The following is a description of a gene set: species: Homo sapiens Tumor growth is associated with a profound alteration of myelopoiesis, leading to recruitment of immunosuppressive cells known as myeloid-derived suppressor cells (MDSCs). Analyzing the cytokines affecting myelo-monocytic differentiation produced by various experimental tumors, we found that GM-CSF, G-CSF, and IL-6 allowed a rapid generation of MDSCs from precursors present in mouse and human bone marrow (BM). BM-MDSCs induced by GM-CSF+IL-6 possessed the highest tolerogenic activity, as revealed by the ability to impair the priming of IFN- -producing CD8+ T cells upon in vivo adoptive transfer. Moreover, adoptive transfer of syngeneic, GM-CSF+IL-6-conditioned MDSCs to diabetic mice transplanted with allogeneic pancreatic islets resulted in long term acceptance of the allograft and correction of the diabetic status. Cytokines inducing MDSCs acted on a common molecular pathway. Immunoregulatory activity of both tumor-induced and BM-derived MDSCs was entirely dependent on C/EBP transcription factor, a key component of the emergency myelopoiesis triggered by stress and inflammation. Adoptive transfer of tumor antigen-specific CD8+ T lymphocytes resulted in therapy of established tumors only in mice lacking C/EBP in myeloid compartment. These data unveil another link between inflammation and cancer and identify a novel molecular target to control tumor-induced immune suppression. We used gene expression analysis to identify those factors, secreted by tumor-infiltrating MDSC, which could drive emathopoiesis. Moreover we compare gene expression profile of tumor-induced MDSC, obtained from either the spleen and the tumor infiltrate of tumor bearing mice, and in vitro bone marrow-derived MDSC. Human Gene Set: GSE21927_SPLEEN_VS_BONE_MARROW_MONOCYTE_BALBC_DN from publication Marigo I, Bosio E, Solito S, Mesa C, Fernandez A, Dolcetti L, Ugel S, Sonda N, Bicciato S, Falisi E, Calabrese F, Basso G, Zanovello P, Cozzi E, Mandruzzato S, Bronte V (PMID 20605485) Genes down-regulated in CD11b+ cells from BALB/c mice: spleen versus bone marrow., and this is the list of marker genes: SMIM17, FKBP11, ANTXR2, TLR10, ENC1, NAB2 (NCBI Gene Id 4665), SLC7A7, RGL3, TIGD4, HPS6, SMO, CDC42EP3, MCM2, BEX5, CNTNAP3B, PCYT1A, CD86, NT5DC1, TNFRSF10B, PCDH11X, TMEM147, BHLHE40, HSD17B10, PLPP2, ID3, F2R, AFDN, DEXI, UHRF1, LRRK1 (NCBI Gene Id 79705), FERMT3, TOB1, CARMIL2, PER3, NICOL1, NECTIN3 (nectin cell adhesion molecule 3), TRAPPC9, SYCE1, JMY, PPP1R13B, ITGAM, DUSP3, PIK3AP1, HDAC1, NOS3, MSRA, JAKMIP1, TESC, DVL1, ARL4D, MGAT4A, BEX2, SNED1, ANKRD26P3, DHRS9, CDAN1 (NCBI Gene Id 979), BACE2, RNASEH2C, TXN, MRPS6, B3GNT7, NEK3, LINC00173 (long intergenic non-protein coding RNA 173), TRIT1, ENTR1, COA7 (NCBI Gene Id 94485), ITGAX, STX10, CARS1, ZBTB38, ESYT3, COA1, APOBEC1, RNF168, PLAG1, CNPY3, CHAD, CSRP1, GAPDH, PDCD5 (NCBI Gene Id 9141), NCR3, TBCB, PPM1N, NUDT19, GLB1, HAUS8, ELK3, FCGR2A, HDAC3, ADAMTS6, MCTP1, PGP, MAOA, FAM200A, BMPR1A, RFLNB, CYTOR, R3HCC1, GLRX, ANKRD13A (ankyrin repeat domain 13A), CASP8, ABHD14A, TMEM163, MROH9, TLCD3A, NDUFB7, EDC4, RAB9BP1, GABRR3, MGLL, MFSD13A (major facilitator superfamily domain containing 13A), NIBAN1, BMP8A, INPP4A, PCDHGB7, CD1D, USP48, S100A10, ZNF793, RGS14, BLVRA, PRAC2, NME3 (NCBI Gene Id 96012), PDCD2L, TPCN2 (NCBI Gene Id 219931), NIPA1, DOK7, MCM5, CD99, MCOLN2, UGCG, EEFSEC, DDAH1, RTKN, SSRP1, IMMP2L, AKAP13, APBB1IP, TXLNB, HYI, FXN, COX7A2L, ANXA7, TNFRSF13B (TNF receptor superfamily member 13B), VAMP1, CCDC86, FBXW7, PDLIM1, ST3GAL3, ZFP90, SDR9C7, ANK3, PLIN2, ASAP1, ST3GAL5, NLRP12 (NLR family pyrin domain containing 12), MAGOH-DT, TOX, SERPINB8, ECHDC1, SPATS2, AIP, KRTAP4-9, MBL2, ZNF575, EVA1C, HSPA1A, HLX, ACP5, MARCKS, SEPTIN7P9, ZNF804A, SGPP1, EDAR, HIPK2, PEX5, MAST3, MOV10, C1QL1, PKIG, DDX28, ZSCAN10, GNAI2 (G protein subunit alpha i2), FOXN3-AS2, MIR22HG, SAMM50, CCN4, STX1B, OPALIN, PITX3, KBTBD8, TMEM216, SOX7, RAC2